The following is a description of a gene set: electronically inferred by orthology from the curated human pathway part of: Signaling by Rho GTPases, Miro GTPases and RHOBTB3 Reactome Pathway: Signaling by Rho GTPases This event has been computationally inferred from an event that has been demonstrated in another species.<p>The inference is based on the homology mapping from PANTHER. Briefly, reactions for which all involved PhysicalEntities (in input, output and catalyst) have a mapped orthologue/paralogue (for complexes at least 75% of components must have a mapping) are inferred to the other species. species: Mus musculus, and this is the list of marker genes: Cenpa, Faf2, Ngef, Ubxn11, Slitrk5, Cct7, Fgd5, Kif2b, Farp1, Picalm, Ppp2r1b, Baiap2l1, Mpp7, Swap70, Baiap2l2, Fmnl2, Vav1, Cenpq, Frs2, Kif5b, Rhoj, Sema4f, Fam13b, Racgap1, Ppp2r5d, Mapk14, Ncf2, Plxnd1, Sh3bp1, Calm1 (NCBI Gene Id 12313), Dync1li2, Arhgef3, Tuba1c, Fam169a, Mapk11, Ccdc115, Bcap31, Arap1, Clasp1, Rhou, Seh1l, Vrk2, Aurkb, Arhgef10, Gja1, Lmnb1, Ctnnb1, Pik3c3, Stam, Pak3, Arhgap28, Ckap4, Wwp2, Letm1, Arhgap33, Tubb4a, Atp6ap1, Sos2, Mrtfa, Pld2, Depdc1b, Rhoh, Pcdh7, Cav1, Lman1, Nox3, Itsn1, Tuba1a, Nudc, Jup, Kidins220, Xpo1, Actr2, Esyt1, Arhgef39, Lin7b, Rbmx, Ska1, Arhgdig, Steap3, Mad1l1, Tuba8, Mis12, Armcx3, Cenpm, Muc13, Pfn1 (profilin 1), Hmox2, Twf1, Slitrk3, Arhgap10, Diaph2, Lbr, Kntc1 (NCBI Gene Id 208628), Tuba3b, Arhgef1, Basp1, Ar, Arhgap22, Ptpn13, Nckipsd, Scfd1, Ndufa5, Arhgef7, Arhgef12, Pak4, Cenpe, Arpc4 (actin related protein 2/3 complex, subunit 4), Wasf1, Plekhg3, Pkn1, Vcp, Flot2, Fgd1, Arhgdib, Cyba, Tubal3, Gopc, Myl9, Tagap, Wasf3, Arhgap26, Akap12, Rnd2, Uaca, Nde1 (nudE neurodevelopment protein 1), Ddx4, Cdc42, Ndc80, Itgb3bp, Dnmbp, Vim, Prkca, Dock5, Men1, Arhgap12, Txnl1 (NCBI Gene Id 53382), Tubb6, Stard13, Cct6a, Cenpn, Zfp512b (NCBI Gene Id 269401), Pgrmc2, Tmod3, Fgd2, Myh10, Klc4, Dvl1, Cdc25c, Ophn1, Ppp2r5b, Tmem87a, Arhgap45, Arhgap8, Plk1, Cct2, Nf2, Tubb4b, Ywhae, Lamtor1 (late endosomal/lysosomal adaptor, MAPK and MTOR activator 1), Arhgef10l, Dlg4, Rac3, Cenps, Fam13a, Dvl2, Rnd1, Dock8, Spc24, Myh14, Trip10, Actr3, Arhgap18, Klc3, Pdpk1, Arhgap15, Plekhg6, Hspe1, B9d2, Myl6, Tuba1b, Rtkn, Ankle2, Ccdc187, Arhgap25, Lck, Tpm3, Aaas, Dsg1a, Mcam, Lrrc1, Vangl2 (NCBI Gene Id 93840), Pik3r2, Cyfip2, Mapk3, Zwilch, Prex1, Ocrl, Evl, Tubb2b, Rhov, Grb2, Noxo1, Ndufs3, Mad2l1, Dock2, Msi2, Rab7, Arhgap9, Ptk2, Spen, Gfod1, Dynll1, Ppp2r5a, Cpd, Nup85, Arhgap19, Actc1, Cenpu, Tuba4a, Csk, Tnfaip1, Gmip, Ywhah (tyrosine 3-monooxygenase/tryptophan 5-monooxygenase activation protein, eta polypeptide), Rhob, Emc3, Arhgap42, Rhpn1, Pde5a, Sfn, Gna13 (guanine nucleotide binding protein, alpha 13), Arpc5, Epha2, Pak6, Cdc37, Noxa1, Rac2, Arhgap11a, Ncf1, Fermt2, Arpc2, Arhgap40, Dvl3, Ktn1, Dock11, Samm50 (NCBI Gene Id 68653), Acbd5, Mtmr1, Stard8, Arhgef17, Ppp1r14a, Emd, Arhgap17, Cenpt, Ndel1, Stk10, Ckb, Nup133, Arhgef15, Fam83b, Flot1 (flotillin 1), Kif2c, Vangl1, Cdh1, Nsfl1c, Wdr6, Dlc1, Arhgap44, Pfn2, Tor1aip1